The following is a description of a gene set: Human Gene Set: GOBP_REGULATION_OF_DNA_RECOMBINATION studied in species Homo sapiens Any process that modulates the frequency, rate or extent of DNA recombination, a DNA metabolic process in which a new genotype is formed by reassortment of genes resulting in gene combinations different from those that were present in the parents., and this is the list of marker genes: PARP1, CD40, POLQ, SMARCAD1, KLHL15, PARP3, SENP3, FANCB, HMCES, PTPRC, KPNA2, OOEP, MSH6 (NCBI Gene Id 2956), PPP4C, KMT5A, PRDM9, IL2, ZNF365, SETD2, RADX, YEATS4, MLH1, HELQ, WRAP53, CLCF1, TNFSF13, KAT5, TRRAP, ING3, ABL1, SHLD3, EPC2, MSH3, KDM1A, RPA2, H1-0, MRE11, SHLD2, TEX15, EP400, USP51, H1-4, KPNA1, ZSCAN4 (zinc finger and SCAN domain containing 4), PLK1, CHEK1, H1-7, ACTB, NDFIP1, H1-2, TERF2IP, ARID2, FUS, ACTR2, PIAS4, TFRC, PELI1 (NCBI Gene Id 57334), PRMT1, H1-9P, HDGFL2, MORF4L2, SKP2, HELB, RTEL1, ZCWPW1, RAD50, WAS, KMT5B, H1-1, SHLD1, RAD51, RAD51AP1, VPS72, KMT5C, RUVBL2, ERCC6, MRGBP, MAGEF1, MORF4L1, MEAF6, WDR48, EXOSC6, IL7R, H1-5, BLM, IL27RA, H1-10, BRD8 (NCBI Gene Id 10902), H1-3, SLC15A4, TP53BP1, PAXIP1, SIRT6, SUPT6H, RMI2, NSD2, TGFB1, CSNK2A1, IL10, TBX21 (NCBI Gene Id 30009), EXOSC3, SPIDR, RUVBL1, UBQLN4, C1QBP, UBE2B, NBN, RECQL5, CGAS, STAT6, MAD2L2, PMS2, DMAP1, H1-8, KHDC3L, ATAD5, TERF2, TNFSF4, FOXP3, ERCC2, PARPBP, EPC1, ACTL6A, ANKLE1, FBH1, MRNIP, CD28, RNF8, RNF126, H1-6, TIMELESS, IL4, MBTD1, APLF, CREBBP, SMCHD1, RIF1, PPP4R2, MSH2, BCL6, FIGNL1 (NCBI Gene Id 63979)